Given this list of marker genes Pip4p1, Ccdc115, Atp6ap1, Vma21 (NCBI Gene Id 67048), Tm9sf4, Tmem199, Tmem9, Atp6v1b1, Aldob, here is a description of the gene set: Mouse Gene Set: GOBP_PROTON_TRANSPORTING_V_TYPE_ATPASE_COMPLEX_ASSEMBLY species: Mus musculus The aggregation, arrangement and bonding together of a proton-transporting V-type ATPase complex, proton-transporting two-sector ATPase complex that couples ATP hydrolysis to the transport of protons across a concentration gradient.